Given this list of marker genes Gstm4, Folh1, Ptges2, Ptges, Mmachc, Lancl1, Gsta1, Gsta13, Gstm3, Gsta2, Gstm5, Gstm2, Mgst2, Gss, Gsr, Gsta5, Ltc4s, Gstm1, Gstm6, Mgst1, Gstm7, here is a description of the gene set: Binding to an oligopeptide. species: Mus musculus Mouse Gene Set: GOMF_OLIGOPEPTIDE_BINDING